The following is a description of a gene set: Mouse Gene Set: GOBP_DEMETHYLATION studied in species Mus musculus The process of removing one or more methyl groups from a molecule., and this is the list of marker genes: Cyp1a2, Cyp3a16 (cytochrome P450, family 3, subfamily a, polypeptide 16), Cyp3a57, Cyp3a13, Jmjd6, Ppme1, Alkbh1, Cyp2d22, Cyp3a59, Cyp3a41a, Mmachc, Kdm1a, Cyp3a11, Por, Alkbh4, Cyp3a44, Cyp3a41b, Phf2, Cyp3a25